The following is a description of a gene set: studied in species Homo sapiens Human Gene Set: GOBP_INTERLEUKIN_17A_MEDIATED_SIGNALING_PATHWAY The series of molecular signals initiated by interleukin-17A binding to its receptor on the surface of a target cell, and ending with the regulation of a downstream cellular process, e.g. transcription., and this is the list of marker genes: IL17A, IL17RC, MAP3K7, IL17RA (NCBI Gene Id 23765), TRAF3IP2, TRAF6